Given this list of marker genes TFE3, ADAMTS10, IL1RN, GLB1, DYM, TMEM53, KCNJ8, COL11A2, ABCC9, COMP, FBN1, SETBP1, ARSB, WNT7A, GUSB, COL11A1, SOST, XYLT1, SERPINH1, GNPTAB, ARSK, NEK9, SMAD4, PTH1R, AMER1, ATP7A, PTDSS1, here is a description of the gene set: Broad ribs Increased width of ribs Human Gene Set: HP_BROAD_RIBS species: Homo sapiens